Given this list of marker genes SNRPG, METTL13, TYMS, CDC7, AP2S1, NEFH, HMGN4, DBI, DMC1, IMPA1, GRHPR, IPO7, CCNB2, SLC29A1, HSP90AB1, FEN1, H2AX, TMED9, RFC4, GBP1, ACTN4, ECI1, GET3, DLGAP5, TPX2, TNIP1, NDUFB8, LDHA, CD63, AK4, PSMB9, TUBG1 (tubulin gamma 1), HNRNPA0, PRIM1, BDH1, STT3A, TXN, PRPS2, WARS1, HADH, SIT1, PCK2, ACOT7, PPP2R1B, YWHAE, NRAS, IMMT, STAMBP, EZH2, FADD, KIFC1, MRPL28, TNFSF14, SHMT2, TIAM1, RRP7A, CKS2, NKG7, ETHE1, NPM3, LYST, HNRNPAB, CENPF, COQ7, DAZL, CCDC6, PCCB, EBNA1BP2 (EBNA1 binding protein 2), DUSP4, CDC25C, MICAL2, ACOT13, SPTSSA, EIF4A1, CHEK1, TP53, CRYZ, AHCY, PARP1, GHITM, TIMM17B, HNRNPF, MCM3, GTF2E2, CKAP5, SRM, SLC16A1, YIF1A, MFSD10, TRIP10, IGFBP2, MRPL40, MATK, CHAF1A, CYB5B, ACAA2, HMGN2, MTHFD1, SEC23IP, KIF11, LTA, SKAP2, MTHFD2, FARSA, POLA1, NME1, TMEM106C, UNG, PLK1, POLR2G, EIF2S1, DYNLL1, CCT5, SUCLA2, PAICS (NCBI Gene Id 647765), CENPE, PDXK, TBCE, ATP5MC3, FSCN1, NHP2 (NCBI Gene Id 55651), FABP5, TUBA1B, CTPS1, CCNE1, CLIC1, TOMM40, MRPL23, BCAT2, PRDX3, PSMB5, NDUFA7, MYL6B, SOCS1, PSMG1, HDGF, PSMA6, UBE2C, RPA2, PGK1, ILK, IDH2, CCNB1, DIXDC1, HAX1, PMVK, TCEAL4, RAB27A, CDC6, MYBL2, MAP4, IPO5, GNPAT, VDAC3, GZMB, LCP2 (NCBI Gene Id 3937), LTBP4, RTL8C, FH, WDHD1, PHGDH, PYCR1, COL6A3, VCP, UBE2S, AURKA, RDX, CIT, EPRS1, COX6A1, HSBP1, GM2A, SYT11, TTF2, LAG3, ENO1, SLC1A5, SORD, NTRK1, HMMR, SRD5A1, BUB1B, PSMD14 (proteasome 26S subunit, non-ATPase 14), CCT6A, PSMD8, SPAG5, AIFM1, PEA15, PSMB2, RUVBL2 (NCBI Gene Id 10856), ANXA5, NDN, PRDX1, CCL5, CDKN3, ATOX1, NIPSNAP1, RFC3 (replication factor C subunit 3), ENO2, here is a description of the gene set: from publication Ghisi M, Corradin A, Basso K, Frasson C, Serafin V, Mukherjee S, Mussolin L, Ruggero K, Bonanno L, Guffanti A, De Bellis G, Gerosa G, Stellin G, D'Agostino DM, Basso G, Bronte V, Indraccolo S, Amadori A, Zanovello P (PMID 21551231) Human Gene Set: GSE26156_DOUBLE_POSITIVE_VS_CD4_SINGLE_POSITIVE_THYMOCYTE_DN studied in species Homo sapiens Genes down-regulated in thymocytes: double positive versus CD4 single positive. Gene expression of Double Positive, and Single Positive CD4+ human thymocytes